Given this list of marker genes PIK3CA (NCBI Gene Id 5290), TRIM37, FRA10AC1, RBM8A, WNT5A, NCF1, DNAJC30, CDK10, NEK9, ASXL1, TMEM270, KCNQ1OT1, PUF60, AKT1, SMC3, LBR, EDEM3, SPTSSA, DIS3L2, METTL27 (methyltransferase like 27), KRAS, IGF2, GTF2I, ROR2 (receptor tyrosine kinase like orphan receptor 2), NOTCH1, NAA10, NXN, LIMK1, EIF2AK4, H19 (H19, imprinted maternally expressed transcript), PLP1, KCNQ1 (potassium voltage-gated channel subfamily Q member 1), DVL3, SLC26A2, FZD2, MED25, RFC2, ELN, CDK13, TBL2, FGFR1, CDKN1C, VPS37D, STX1A, MTOR (mechanistic target of rapamycin kinase), GTF2IRD1, NF1, EIF4H, BUD23, CLIP2, EPHB4 (EPH receptor B4), TGFB3, DVL1, STAMBP, BAZ1B, SETBP1 (NCBI Gene Id 284262), FKBP6, GTF2IRD2, RASA1, GNAQ, ASXL2 (ASXL transcriptional regulator 2), here is a description of the gene set: Human Gene Set: HP_CAPILLARY_MALFORMATION studied in species Homo sapiens A capillary malformation is a flat, sharply defined vascular stain of the skin. It may cover a large surface area or it may be scattered and appear as little islands of color. In a capillary maformation, the predominant vessels are small, slow-flow vessels (i.e., arterioles and postcapillary venules). Capillary malformation